Given this list of marker genes EPPK1, JUP, ERBIN, DST (NCBI Gene Id 80105), PLEC, LAMA3 (NCBI Gene Id 3909), COL17A1, ITGB4, here is a description of the gene set: species: Homo sapiens A cell-substrate junction (attachment structure) found in epithelial cells that links intermediate filaments to extracellular matrices via transmembrane complexes. In vertebrates, hemidesmosomes mediate contact between the basal side of epithelial cells and the basal lamina. In C. elegans, hemidesmosomes connect epithelial cells to distinct extracellular matrices on both the apical and basal cell surfaces. Human Gene Set: GOCC_HEMIDESMOSOME